The following is a description of a gene set: The process in which the anatomical structures of the hindgut are generated and organized, during the embryonic phase. Mouse Gene Set: GOBP_EMBRYONIC_HINDGUT_MORPHOGENESIS studied in species Mus musculus, and this is the list of marker genes: Tcf7, Dact1, Tcf7l2, Hoxd13, Hoxa13